The following is a description of a gene set: Human Gene Set: GOBP_SPINAL_CORD_PATTERNING species: Homo sapiens The regionalization process that regulates the coordinated growth and establishes the non-random spatial arrangement of the spinal cord., and this is the list of marker genes: ASCL1, RELN, DMRT3, IFT122, SUFU, LHX3, GLI2, GLI3, GDF11, DLL4, SOX1, FOXN4, DBX1, INTU, CHRD, SHH, NKX2-2, SMO